Given this list of marker genes CTSK, ATP6V1B2, TONSL, MIA3, EDARADD, TEKT3, KCNJ2, LRP6, WNT10B, NSD1, SLC37A4, AXIN2, GJA1, SUMO1, NPHS1, PIGF, WNT10A, ADAMTSL1, FGFR1, EDA, ANKH, FAM20A, TBC1D24, APC2, RECQL, RUNX2, MSX1, ROR2, IRF6, SOX4, TGFA, PAX9, SMARCB1, here is a description of the gene set: studied in species Homo sapiens Delayed tooth eruption affecting the secondary dentition. Human Gene Set: HP_DELAYED_ERUPTION_OF_PERMANENT_TEETH Delayed eruption of permanent teeth